The following is a description of a gene set: The Rho family of small guanine nucleotide binding proteins is one of seven phylogenetic branches of the Ras superfamily, which, besides Rho, Miro and RHOBTB3 also includes Ran, Arf, Rab and Ras families. Miro GTPases and RHOBTB3 ATPase are sometimes described as Rho family members, but they are phylogenetically distinct. Phylogenetically, RHO GTPases can be grouped into four clusters. The first cluster consists of three subfamilies: Rho, RhoD/RhoF and Rnd. The second cluster consists of three subfamilies: Rac, Cdc42 and RhoU/RhoV. The third cluster consists of the RhoH subfamily. The fourth cluster consists of the RhoBTB subfamily. Based on their activation type, RHO GTPases can be divided into classical (typical) and atypical. Classical RHO GTPases cycle between active GTP-bound states and inactive GDP-bound states through steps that are tightly controlled by members of three classes of proteins: (1) guanine nucleotide dissociation inhibitors or GDIs, which maintain Rho proteins in an inactive state in the cytoplasm, (2) guanine nucleotide exchange factors or GEFs, which destabilize the interaction between Rho proteins and their bound nucleotide, the net result of which is the exchange of bound GDP for the more abundant GTP, and (3) GTPase activating proteins or GAPs, which stimulate the low intrinsic GTP hydrolysis activity of Rho family members, thus promoting their inactivation. GDIs, GEFs, and GAPs are themselves subject to tight regulation, and the overall level of Rho activity reflects the balance of their activities. Many of the Rho-specific GEFs, GAPs, and GDIs act on multiple Rho GTPases, so that regulation of these control proteins can have complex effects on the functions of multiple Rho GTPases. Classical RHO GTPases include four subfamilies: Rho (includes RHOA, RHOB and RHOC), Rac (includes RAC1, RAC2, RAC3 and RHOG), Cdc42 (includes CDC42, RHOJ and RHOQ) and RhoD/RhoF (includes RHOD and RHOF). Atypical RHO GTPases do not possess GTPase activity. They therefore constitutively exist in the active GTP-bound state. Atypical RHO GTPases include three subfamilies: Rnd (includes RND1, RND2 and RND3), RhoBTB (includes RHOBTB1 and RHOBTB2), RhoH (RHOH is the only member) and RhoU/RhoV (includes RHOU and RHOV). Members of the Rho family have been identified in all eukaryotes. Among Rho GTPases, RHOA, RAC1 and CDC42 have been most extensively studied.<br><br>RHO GTPases regulate cell behavior by activating a number of downstream effectors that regulate cytoskeletal organization, intracellular trafficking and transcription. They are best known for their ability to induce dynamic rearrangements of the plasma membrane-associated actin cytoskeleton. Beyond this function, Rho GTPases also regulate actomyosin contractility and microtubule dynamics. Rho mediated effects on transcription and membrane trafficking are believed to be secondary to these functions. At the more macroscopic level, Rho GTPases have been implicated in many important cell biological processes, including cell growth control, cytokinesis, cell motility, cell-cell and cell-extracellular matrix adhesion, cell transformation and invasion, and development. One of the best studied RHO GTPase effectors are protein kinases ROCK1 and ROCK2, which phosphorylate many proteins involved in the stabilization of actin filaments and generation of actin-myosin contractile force, such as LIM kinases and myosin regulatory light chains (MRLC). The p21-activated kinase family, which includes PAK1, PAK2 and PAK3, is another well characterized family of RHO GTPase effectors involved in cytoskeleton regulation. Protein kinase C related kinases (PKNs), PKN1, PKN2 and PKN3 play important roles in cytoskeleton organization, regulation of cell cycle, receptor trafficking, apoptosis, and transcription. Citron kinase (CIT) is involved in Golgi apparatus organization through regulation of the actin cytoskeleton and in the regulation of cytokinesis. Kinectin (KTN1), a kinesin anchor protein, is a RHO GTPase effector involved in kinesin-mediated vesicle motility, including microtubule-dependent lysosomal transport. IQGAP proteins, IQGAP1, IQGAP2 and IQGAP3, are RHO GTPase effectors that modulate cell shape and motility through regulation of G-actin/F-actin equilibrium, regulate adherens junctions, and contribute to cell polarity and lamellipodia formation. WASP and WAVE proteins, as well as formins, are RHO GTPase effectors that regulate actin polymerization and play important roles in cell motility, organelle trafficking and mitosis. Rhotekin (RTKN) and rhophilins (RHPN1 and RHPN2) are RHO GTPase effectors that regulate the organization of the actin cytoskeleton and are implicated in the establishment of cell polarity, cell motility and possibly endosome trafficking. Cytoskeletal changes triggered by the activation of formins and RTKN may lead to stimulation of SRF-mediated transcription. NADPH oxidase complexes 1, 2 and 3 (NOX1, NOX2 and NOX3), membrane associated enzymatic complexes that use NADPH as an electron donor to reduce oxygen and produce superoxide (O2-), are also regulated by RHO GTPases. Every RHO GTPase activates multiple downstream effectors and most effectors are regulated by multiple RHO GTPases, resulting in an elaborate cross-talk. part of: Signaling by Rho GTPases, Miro GTPases and RHOBTB3 Reactome Pathway: Signaling by Rho GTPases studied in species Homo sapiens, and this is the list of marker genes: PPP2R5B, TUBB1, H2BC14, WASF2, ARHGEF39, CSK, CDCA8, CKAP4, ARHGAP32, CTNNA1, PTPN13, PIN1, TIAM1, FILIP1, NISCH, MACO1, WAS, ROCK2, NOXO1, ARHGEF3, ACTG1, FNBP1L, SH3BP1, BUB1B, MYO9B, SCFD1, SGO1, PRKCZ, SRF, ALS2, HSPE1, FARP2, PLXNA1, MAPRE1, ARHGAP29, NDEL1, ARHGEF12, BCR, CDC42EP2, TUBB4B, FLOT2, VAPB, XPO1, EVL, KIF2B, PMF1, TUBA3E, CENPQ, AHCTF1, NCKAP1L, PGRMC2, PHIP, RND1, CENPM, ERBIN, DSN1, TMOD3, ARHGAP23, MYH9, PRKCD, H3C15, ARHGAP9, TUBA1C, ITGB1, H2AC7, ROCK1, FGD1 (FYVE, RhoGEF and PH domain containing 1), KIF2A, BAIAP2L1 (NCBI Gene Id 55971), DLG4, CPNE8, NOX1, SEC13 (SEC13 homolog, nuclear pore and COPII coat complex component), GARRE1, NCK2, WIPF2, RHOV, BCAP31, MYL9, GOLGA3, GJA1, STK10, STX5, SLITRK3, DYNC1H1, PPP2R5E, YWHAZ, FAM91A1 (NCBI Gene Id 157769), ARPC2, S100A8, EMC3 (ER membrane protein complex subunit 3), RCC2, PCDH7, KIF2C, CAV1, WIPF3, ARHGEF19 (Rho guanine nucleotide exchange factor 19), CDC25C, SPTAN1, PRC1, NUP107, CENPL, NDC80, TUBA1A, ARHGAP15, PLEKHG6, DYNC1LI2, CTTN, CENPF, ARHGAP28 (Rho GTPase activating protein 28), PTK2, ARHGAP8, NUF2, RANBP2, SH3PXD2A, GRB7, SYDE1, PLK1, CDC42EP3, PLEKHG3, NOX3, RNF20, NUP85, ARHGEF11, CEP97, TUBB8B, DOCK10, RRAS2, CYBA, ZNF512B, PARD6B, ACTB, ARHGAP39, BLTP3B, CDC42BPB, RHOJ, KCTD13, H3-3A, RAC2, MAD2L1, FMNL1, ARPC1A, DOCK2, PIK3R4, RHOU, ARHGEF18, CENPT, TWF1, RHOC, DVL3, TXNL1 (NCBI Gene Id 9352), H2BC13, DOCK4, KLK2, TUBB2B, LCK, DSP, RHOB, ARHGAP6, SRGAP1, H2AC14, KALRN, PIK3CA, PLEKHG4, CDC42BPA, SCRIB, BAIAP2, STARD13, B9D2, HGS, OSBPL11, ATP6AP1, WASF1, TEX2, H2BC1, CLASP2, CPSF7, H2BC11, MTMR1, DIAPH3, TUBB6, ABR, EPSTI1, FAM13A, RHOG, FRS3, KCTD3, AKAP12, RBMX, FMNL2, H2BC15, DOCK9, ARHGAP10, FGD3, ROPN1, ARHGEF6, ERCC6L, ARHGAP40, VRK2, PIK3R3, ARHGAP20, SKA1, ACTR3, ACTC1, RHOBTB2, PPP2R1B (protein phosphatase 2 scaffold subunit Abeta), H2AX, CCT6A, YKT6 (NCBI Gene Id 63236), DYNC1I1, SOS1, FMNL3, RHPN2, CENPH, NDUFS3, MYH14, VAMP3, CDKN1B, PLEKHG1, RAC1, ARHGAP42, CDC42EP5, ARPC5, DLC1, ITSN1, OCRL, SPC25, CYBB (cytochrome b-245 beta chain), NUP133, SOS2, RHOA, NSL1, STBD1, NOXA1, DLG5, ARHGAP25, PLD1, CENPI, ARHGEF2, LMNB1, DVL2, TUBA3D, RND2, LBR, RHOQ (ras homolog family member Q), CENPN, CLIP1, SENP1, H2BC3, KIF5B, CKAP5, TJP2 (tight junction protein 2), ITGB3BP, WASL, ARAP2, H2BC12L, PAK4, TUBA8, PPP2CA, KNL1, STARD8, RBBP6 (RB binding protein 6, ubiquitin ligase), ARHGEF7, ANLN, MCF2L, KIF14, H2AC4, STOM (stomatin), NGEF, MYL6, GMIP, ITSN2, VMA22, TAGAP, ARHGAP24 (Rho GTPase activating protein 24), MAP3K11, MCAM, ARMCX3, JUP, JAG1, KIF18A, MYH10, PEAK1, ARHGDIA, ARHGAP5, TAOK3, UACA, MAPK14, VAV3, VAV2, ARHGAP27, NCKAP1, SRC, RHOBTB1, CDC42EP1, ARHGAP33, ZWILCH (NCBI Gene Id 55055), GPS1, C1QBP, SGO2, ARHGAP18, RND3 (Rho family GTPase 3), LEMD3, NET1, KTN1, VANGL1, PLXNB1, LIMK2, DOCK8, ARHGEF1, MPP7, PLEKHG2, HMOX2, SLC1A5, SPDL1, MAPK11, SPTBN1, PREX1, TUBB3, ANKFY1, WDR11, ABL2, KLC3, RALBP1, PPP2CB, KIDINS220, CCDC187, PAK1, IL32, FRS2, ARHGAP17, GFOD1, CPD, ARHGAP11B, TUBA4A, PPP1CC, ACBD5, SRGAP2, ARHGAP1, H4C1, ACTR2, ARHGAP11A, NUP37, DYNC1LI1, H2AZ2, CAVIN1, NCKIPSD, H2BC4, PPP2R5A, CENPO, KLC4 (NCBI Gene Id 89953), DDX39B, WASF3, ARHGAP19, NSFL1C, SWAP70, CCDC88A, PLEKHG4B, PDE5A, YWHAE, RAC3, SNAP23, COPS2, ANKLE2, YWHAG, WDR81, ARAP1, S100A9, SCAI, KLK3, IQGAP2, ARPC3, NUDC, DOCK11, DDX4 (NCBI Gene Id 54514), CLTC, ARHGAP22, ZW10, NF2, FGD2, NCF2, ARHGAP44, HINT2, YWHAQ, ARHGAP21, RASGRF2, BAIAP2L2, H2AC20, DEPDC1B, TRIP10, PKN2, PRKCB, ABI1, DIAPH2, CCT2, DAAM1, ARPC4, MTR, TOR1AIP1 (NCBI Gene Id 84764), YWHAB, PAK6, OPHN1, MCF2, IQGAP3, AKAP13, TPM4, CENPP, RHOH, PKP4, VCP, SPATA13, MYH11, PIK3C3, H2AC18 (NCBI Gene Id 8337), H2BC26, PARD6A, CTNNB1, NIPSNAP2, MYO6, ARHGEF9, STIP1, TUBA4B, PPP2R5C, AMIGO2, EMD, EFHD2, PFN1, DYNLL2, TIAM2, TMPO, TMEM87A, LRRC1, BTK, BASP1, SYDE2, SH3RF1, DDRGK1, WHAMM, CHN2, STMN2 (stathmin 2), ALDH3A2, MTX1, FGD5, RHPN1, DIAPH1, PIK3R2, NUP160, NCOA2, ARL13B, RAPGEF1, DOCK3, ARHGAP45, ARFGAP3, PPP1R14A, COPS4, INCENP, LETM1, DBT, TAX1BP3, H2BC17, POTEE, H3C1, FERMT2 (NCBI Gene Id 10979), CDC37, PPP1R12B, FLNA, MSI2, NCF1, VIM, ARAP3, STAM, SLITRK5, MUC13, PPP1R12A (NCBI Gene Id 4659), ARHGEF10L, SFN, ARHGEF10 (NCBI Gene Id 9639), PIK3R1, HNRNPC, CENPE, ELMO2, BUB1, NDE1, DSG2, VANGL2, CENPU, PRKCA, CYFIP1, TPM3, H2AB1, KDM1A, RHOF, GOLGA8R, SLK, SOWAHC, KDM4C, CDC42SE2, ARHGAP35, CKB, CDH1, CFL1, FAM169A, H2BC12, NHS, MYL12B, ARHGEF26, DOCK5, RALGAPA1, RTKN, CDC20, STEAP3, ARHGAP30, SEH1L, KIF5A, ARFGAP2, DST, WIPF1, ARHGEF16, H2AJ, FAM83B, ARHGEF15, DSG1, DYNC1I2, CLASP1, FARP1, RPS27, MOSPD2, FLOT1, ARPC1B, MAD1L1, AURKB, PAK3, DOCK7, CHN1, HSP90AB1, ADD3, MYLK, UBXN11, TUBB2A, ZWINT (ZW10 interacting kinetochore protein), CCP110, GRB2, FGD4, GIT1, BIRC5 (NCBI Gene Id 332), BRK1, DOCK1, EPHA2, AR, RAB7A, ABL1, H2AC6, H2BC21, MIS12, PTK2B, TNFAIP1, CCT7, CYFIP2, ARHGEF4, PFN2, TUBAL3, ABI2, TMEM59, CENPA, PAK5, TUBB4A, ECT2, USP9X, H2BC5, PPP2R1A, CFTR, ARHGAP31, TUBA3C, PKN1, GOPC, ARHGAP26, PKN3, WWP2, ARHGEF17, LIMK1, MEN1, DNMBP, ARHGEF28, SAMM50, ACTN1 (NCBI Gene Id 87), VAV1, MYO9A, PAK2, SPC24, PICALM, DOCK6, CDC42 (cell division cycle 42), SHKBP1, FAM135A, CENPS, FAM13B, H2BC9, DBN1, FNBP1, MAPK1, RASAL2, ARHGDIB, CAPZB, AAAS, KLC1, TAOK1, SRRM1, CENPC, DVL1, ARHGAP12, CENPK, NUP43, ANKRD26, NDUFA5 (NCBI Gene Id 80046), LAMTOR1, PRAG1, TRIO, MAPK3, ZAP70, ARHGAP4, PLXND1, ABCD3, PAFAH1B1, NCF4, STK38, PREX2, MRTFA, CUL3, DYNLL1, CIT, ESYT1, GIT2, ARHGEF40, STAM2, CDC42EP4, PPP1CB, SRGAP3, SLC4A7, SHMT2, CALM1, PLEKHG5, DEF6, WDR6, TFRC, TRA2B, TUBB8, SPEN, IQGAP1, YWHAH, SEMA4F, OBSCN, RHOD, BUB3, LMAN1, KLC2, PDPK1, PLD2, RACGAP1, LIN7B, ARHGEF5, NUP98, NCK1, PPP2R5D, RANGAP1, KNTC1, GNA13 (G protein subunit alpha 13), ARHGDIG, ARHGEF25, SKA2, FAF2, HSP90AA1, WDR91, TUBA1B